Given this list of marker genes RAB11FIP4, WASF2, U2SURP, MFHAS1, C7, TRAF4, NCS1, RGS7, SLC36A1, IFT80, CHST2, EXOSC5, SCN1B, DHX15, DZIP3, SYDE1, CNTD1, HYAL4, KRT74, PIK3C2B, RIMS4, ATP6V1A, STAT3, PTPN7, PTPRJ, GALK1, EXOG, TGM4, LRRC59, CHD6, TSPAN6, GCLM, CBX6, KLF6, PDS5A, LINC02914, FHIP1A, VCAN, MITF, KDM2A, ALX4, PAPOLG, LDLRAP1, KRT6A, EBF3, PALM2AKAP2, GIN1, HTR3E, FCHSD2, CAPN5, LRP6, NHEJ1, TTBK1, ADCK1, LARP4B, CA13, BCAT1, CEP85, CREB1, TMEM100, PIP5K1A, ING4, LMBRD1, SCN8A, PRDM9, DCUN1D1, SPAG17, MTA2, SDC3, MMP15 (NCBI Gene Id 4324), STRADB, RNF144B, EDIL3, KRTAP4-12, F2RL2, INKA2, PRR3, SOCS3, FAM131B, MXI1, NONO, MOB3C, NTRK2, SLC25A35, HTR6, DIPK2B, USP2, AGPAT4, CUL2, KIF1A, PPP2R1B, INO80D, KRT6C, ATXN1, MUL1, ELL, POU2F2, NCOA1, MOB3A, MBD6, NR6A1, EEIG1, PPP1R9B, EIF4G3, FA2H, SHC1, BCAS4, NFASC, FUBP3, CACNA2D4, FOXP4, PDE1B (NCBI Gene Id 5153), RAB2B, RNF4, TBCEL, THEM5, here is a description of the gene set: Human Gene Set: MIR650 studied in species Homo sapiens from publication Chen Y, Wang X (PMID 31504780) Genes predicted to be targets of miRBase v22 microRNA hsa-miR-650 in miRDB v6.0 with MirTarget v4 prediction scores > 80 (high confidence targets).